Given this list of marker genes Sfrp1 (secreted frizzled-related protein 1), Tgfb1, Oxtr, Bcl2l2, Col1a1, Sprr2f, Strn3, Tacr3, Pou4f1, Gpi1, Msx2, Sprr2d, Endog, Abcb1a, Mbd3, Mapk15, Egfr, Ruvbl2, Sstr2, Rara, Ghsr, Cryab, Nos3, Hnrnpd, Ptgs2, Ihh, Nr2f2, Oxt, Cxcl2 (C-X-C motif chemokine ligand 2), Mecp2, Grn, Ppp1r9b (NCBI Gene Id 217124), Hpgd, Zfp703, Stat5b, Lcor, H2az1, Sprr2a1 (small proline-rich protein 2A1), Errfi1, Kcnj11, Sprr2b, Postn, Txnip, Mmp15, Htr5a (NCBI Gene Id 15563), Prdm2, Gpx4, Calr, F7, Myod1, Casp3, Ass1, Cd38, Ccl2, Gjb2, Fgf10, Gria1, Rgs9, Tacr1, Dhh, Gja1, Cat, Stat3, Mbd2, Gstp1 (NCBI Gene Id 14870), Sprr2e, Slc6a4, Ncoa3, Ggt1, Th, Sprr2c-ps, Fosl2, Wnt7a, Ghr, Crhbp, Stxbp1, Aifm1, Ogg1 (8-oxoguanine DNA-glycosylase 1), Gper1, Cyp19a1, Foxa1, Kat5, Cyp1b1, Il10, Esr1, Sstr1, Dnmt3a, Nqo1, Hspa8, Myog, Nrip1, Drd2 (NCBI Gene Id 13489), Ptch1, Gpx1, Socs2 (NCBI Gene Id 216233), Mmp2, Hsf1, Map1b, Igfbp2, Csn1s1, Prkca, Ccdc62, Gh, Ezh2, Bmp7, Cdkn1b, Pou4f2, Itga2, Sstr3 (NCBI Gene Id 20607), Casp9, Sprr2g, Esr2, Penk, Ramp3, Ucn, Ccna2 (NCBI Gene Id 99481), Ncoa1, Aldh1a2, Kif18a, Ugt1a1, Ctnnb1, Areg, Pcna, Ptgfr, Fam210b, Lep, here is a description of the gene set: species: Mus musculus Mouse Gene Set: GOBP_RESPONSE_TO_ESTRADIOL Any process that results in a change in state or activity of a cell or an organism (in terms of movement, secretion, enzyme production, gene expression, etc.) as a result of stimulus by estradiol, a C18 steroid hormone hydroxylated at C3 and C17 that acts as a potent estrogen.